The following is a description of a gene set: Keratinization Human Gene Set: REACTOME_KERATINIZATION studied in species Homo sapiens, and this is the list of marker genes: KRTAP20-1, KRT84, KRTAP10-11, KRTAP5-3, KRTAP4-11, SPRR1A, ST14, KRTAP11-1, KRT17, KRT6A, FURIN, KRTAP10-7, KRTAP10-12, KRTAP9-6, LCE6A, KRTAP19-1, KRT5, KRTAP3-2, SPRR2G, KRT7, KRT32, KRTAP13-3, KRTAP19-7, PKP1, LCE2C, DSC3, DSP, KRT31, KRT34, PKP2, KRT73, SPINK6, KRTAP21-2, KRTAP4-4, KRTAP5-8, FLG, KRTAP19-5, KRTAP5-9, KRT79, KRTAP29-1, LCE5A, KRT19, CASP14, KRTAP10-4, KRT83, KRTAP27-1, DSG4, LCE1A, KRTAP5-7, LCE2D, KRTAP10-10, KRT25, KRTAP16-1, KRTAP8-1, KRT85, KRTAP13-2, SPRR2D, KRT27, KRT35, LCE1F, SPINK5, KRTAP10-2, SPRR1B (NCBI Gene Id 6699), KRTAP1-3, LIPK, LELP1, KRTAP5-2, KRTAP2-3, LCE1C, KRTAP5-5, KRT6C, KRTAP24-1, DSG3, KRT18, KRTAP20-2, KRT6B, KRTAP13-4, LORICRIN, KRTAP12-4 (NCBI Gene Id 386684), KRT82, KRT3, KRTAP21-3, KRTAP19-3, KRT16, KRT38, KRTAP2-2, DSC1, DSG2, KRTAP4-5, SPRR2E, KRT23, KRTAP9-9, KRTAP5-10, PKP3, LCE3A, KRTAP4-6, KRTAP9-1, KRT33B, KRTAP13-1, KAZN, KRT1, DSC2, LCE3D, KRT39, KRT2 (keratin 2), KRTAP15-1, LIPJ, TGM1, TGM5, PCSK6, KRTAP4-9, KRTAP5-4, KRTAP5-11, KRTAP1-4, LCE1B, KRT24, KLK13, PI3, KRT76, KRTAP9-4, KRT81, KRTAP4-7, LCE2B, KRTAP10-3, DSG1, KRTAP12-3, KRTAP2-1, KRTAP5-6, IVL, LCE1E (late cornified envelope 1E), KRTAP10-6, KRT86, LCE1D, KRTAP10-5 (keratin associated protein 10-5), KRTAP12-2, KRTAP25-1, LCE4A, PKP4, KRT10, KLK5, KRT74, CDSN, KRT9, KRT15 (keratin 15), KRTAP9-3, KRTAP2-4, KRT37, CELA2A, KRTAP10-9, KRT75, KRT40, KRTAP19-2, KRTAP4-1, CAPN1, KRT80, KRTAP9-2, KRTAP26-1, KRTAP10-1, KRTAP4-2, KRT77, KRTAP19-8, EVPL, KRT72, KRTAP19-4, KRTAP4-3, KRTAP1-1, KRT12, KLK8, PPL, KRTAP3-3, KRTAP17-1, PRSS8, KRTAP9-7, LCE3E, KRTAP5-1, CSTA, LCE2A, KRT28, SPRR2A, KRT26, KRT33A, JUP, KRTAP6-3, SPINK9, KRTAP6-1, KRT71, KRT8, KRTAP22-1, KRTAP9-8, KRTAP10-8, RPTN, KRTAP6-2, KRTAP3-1, KRT14, LIPN, KRTAP21-1, PERP, LCE3B, KRT13, SPRR3, KLK14, LCE3C, KRTAP12-1, KRT36, KLK12, KRTAP1-5, KRTAP23-1, KRT78, KRTAP19-6, CAPNS1, TCHH, KRT4, KRTAP4-8, SPRR2B, KRT20, LIPM, SPRR2F